Given this list of marker genes Nudt17, Aldh1l2, Rpia, Taldo1, Aldh1l1, Nudt13, Tigar, Rpe, Mdh1, Hsd11b1, Aco1, Pcx, Nadk, Slc25a51, Pgls, Nampt, Noct, Nmnat2, Ncf2, Mtor, Gck, Idh2, Acacb, Nmrk1 (NCBI Gene Id 225994), Nadk2, Tkt, Trp53, Me1, Cyb5r4, Prps2, G6pd2, Rptor, Nmrk2, Rbks, Aldob, Me2, Dcxr, Idh1, H6pd, G6pdx, Hnf1a, Nudt12, Shpk, Ncf1, Pgd, Nnt, Fmo2 (NCBI Gene Id 98665), Prps1, Mlst8, here is a description of the gene set: The chemical reactions and pathways involving nicotinamide adenine dinucleotide phosphate (NADP+), a coenzyme that interconverts with its reduced form, NADPH, in many redox and biosynthetic reactions. studied in species Mus musculus Mouse Gene Set: GOBP_NADP_METABOLIC_PROCESS